Given this list of marker genes MBNL1, LRRC72, LRP5, RENBP, KHDRBS3, SNX30, HIC1, NKTR, HAUS4 (NCBI Gene Id 54930), SNN, RGS2, CALHM4, ZFPM1, TBC1D9, DIPK1A, IER5L, CAMK2G, HOXC6, PCYT1A, ACAP1 (NCBI Gene Id 9744), RGS13, EPHB2, PDGFA, DTX1, SLC17A5, NRGN, VASP, SLC8B1 (NCBI Gene Id 80024), NFATC1, ADAM8, KCNJ12, B3GNT7, LIN28A, S1PR3, ADGRE5, CBX2, SRD5A3, WFIKKN1, KRTCAP3, UBE2D1, LYRM7, TSPAN14, SP6, LZTFL1 (NCBI Gene Id 54585), SPP1, TUT4, SFXN3, KLRC2, CD86, VCL, CD84, RASD1, SGSH, ZNF365, TRIB2, NEAT1, COQ8A, RCHY1, ITGAV, KMT2E, SIAE, MIDEAS, CTSB, EGFL6, SGK1, MAST3, BACH2 (NCBI Gene Id 653980), PLCG1, TWSG1, DDIT4, FOXJ2, SRPK2, RMND5B, TNKS1BP1, EPHX1, CSF1R, KLF2, SUN2, PPP1R3G, TECPR1, SENP7, POU6F1, TCIRG1, CPNE8, TSC22D1 (NCBI Gene Id 8848), EXOC2, PER1, FCSK, PHF1, DGKD, FIBCD1, DSTYK, CERK, PLD2, ARL10, NFIC, NR4A2, HPCAL1, B4GALT1, RETREG1 (NCBI Gene Id 96119), DUSP2, KLHL24, SUSD6, TPRA1, CNKSR1, TBL1XR1, PEA15, IRS2, LAT2, ZNF516, PNRC1, BACH1, RNF122, TUBB2B, MINDY2, XIST, CNOT8, SNAP29, CD27, WDR26, TMC6, B3GNT5, GIGYF1, RAP2B, SRRD, PTK2B, SMAD3, GDI1, IRF2BP2, CLK1, PDE2A, PLK2, CHST15, ABAT, PTOV1, BEX3, EGR3, PLA2G15, ACTRT2, L1CAM, TNRC18, TSC22D3, SLC6A15, IRF2BPL, ABCG1, CFAP299, SNAI3, TBC1D2B, TXNDC8, VEGFB, HOPX, SLX4, PLD3, LYL1, ATP6V0D1, GRIP1, STEAP1, PHLPP1, MYO1C, IL6R, CABLES1, GSE1, BICRAL, RBPJ, ZNF667, TIMP2, VPS37B, INPP5D, SARS1, TRIM11, DAPL1, MSN, TBC1D4, ZNF768, TPST2, CR2, FCMR, LDLRAP1 (NCBI Gene Id 81862), IER2, FOSL2, DMXL1, RHOF, STK10, VAMP2, CTSA, PAPOLG, GPR137B, LASP1, CSTB, TGFB1, MALAT1, LOXL3, SFT2D2, IRAK2, GRAMD4, RAB3GAP2, PPCDC, CXXC5, LLGL2, FYN, here is a description of the gene set: Human Gene Set: GSE43863_DAY6_EFF_VS_DAY150_MEM_LY6C_INT_CXCR5POS_CD4_TCELL_UP from publication Hale JS, Youngblood B, Latner DR, Mohammed AU, Ye L, Akondy RS, Wu T, Iyer SS, Ahmed R (PMID 23583644) Genes up-regulated in Ly6c int CXCR5+ CD4 T cells: effector during acute infection of LCMV versus memory. CD4 T follicular helper (Tfh) cells provide the required signals to B cells for germinal center reactions that are necessary for longlived antibody responses. However, it remains unclear whether there are CD4+ memory T cells committed to the Tfh lineage after antigen clearance. Using adoptive transfer of antigen-specific memory CD4+ subpopulations (based on CXCR5 and Ly6c expression)in the LCMV infection model, we found that there are distinct memory CD4+ T cell populations with commitment to the Tfh and Th1 lineages. Our conclusions are based on gene expression profiles, epigenetic studies and phenotypic and functional analysis. The gene expression profiles of virus-specific CD4 T cell subets at effector and memory stages is presented here. studied in species Homo sapiens